The following is a description of a gene set: species: Homo sapiens Reactome Pathway: HDL remodeling part of: Plasma lipoprotein remodeling HDL (high-density lipoprotein) particles play a central role in the reverse transport of cholesterol, the process by which cholesterol in tissues other than the liver is returned to the liver for conversion to bile salts and excretion from the body and provided to tissues such as the adrenals and gonads for steroid hormone synthesis.<br>ABCG1 mediates the movement of intracellular cholesterol to the extracellular face of the plasma membrane where it is accessible to circulating HDL (Vaughan & Oram 2005). Spherical (mature) HDL particles can acquire additional molecules of free cholesterol (CHOL) and phospholipid (PL) from cell membranes.<br>At the HDL surface, LCAT (lecithin-cholesterol acyltransferase) associates strongly with HDL particles and, activated by apoA-I, catalyzes the reaction of cholesterol and phosphatidylcholine to yield cholesterol esterified with a long-chain fatty acid and 2-lysophosphatidylcholine. The hydrophobic cholesterol ester reaction product is strongly associated with the HDL particle while the 2-lysophosphatidylcholine product is released. Torcetrapib associates with a molecule of CETP and a spherical HDL particle to form a stable complex, thus trapping CETP and inhibiting CETP-mediated lipid transfer between HDL and LDL.<br>Spherical HDL particles can bind apoC-II, apoC-III and and apoE proteins., and this is the list of marker genes: ALB, ABCG1, APOA1, LIPG, APOC3, CETP, PLTP, APOE, APOC2, LCAT